Given this list of marker genes Wnt11, Trim28, Vangl2, Sfrp1, Zfp568, Wnt5a, Sfrp2, Sfrp5, here is a description of the gene set: The morphogenetic process in which an epithelium narrows along one axis and lengthens in a perpendicular axis contributing to the lengthening of the axis of an organism. studied in species Mus musculus Mouse Gene Set: GOBP_CONVERGENT_EXTENSION_INVOLVED_IN_AXIS_ELONGATION